Given this list of marker genes PYROXD1, NEFL, GAN, PMP22, STIM1, FLVCR1, DARS2, CHCHD10, DDHD1, COA7, MFN2, KIF1B, POGLUT1, MCM3AP, SPG11, EMD, TMEM240, ALDH18A1, PDK3, SMN1, FZD6, CFL2, FARS2, SPG21, MAG, HEPACAM, LMNA (NCBI Gene Id 7816), TGM6, MECP2, GNB4, NDUFA13, MAP3K20, CWF19L1, KY, SLC5A7 (NCBI Gene Id 60482), CCDC88C, ERLIN2, FZD4, ACTN4, DNA2, GDAP2, SURF1, POMT1, CHKB, ATP1A1, PINK1, PMP2, TOR1AIP1, PRX, DAB1, HNRNPDL, MYOT, TFG, MYH7, IGHMBP2, CPT1C, GRM1, PDE8B, BSCL2, PDYN, AFG3L2, COX6A1, SYT14 (NCBI Gene Id 255928), HSPB3, WARS1, TENM4, GARS1, ALG14, REEP2, FBXO7, RETREG1 (reticulophagy regulator 1), GBE1, TMEM43, MPZ, SIGMAR1, PNPLA2, DPAGT1, SLC25A4, FAT2, ALG2, AIFM1, PEX2, RYR1, EEF2, AR, TIA1, KBTBD13, SETX, DCTN1, TTN, ORAI1, IBA57, ADSS1, KCNC3, MARS1, LRSAM1, MTPAP (mitochondrial poly(A) polymerase), GJB1, TRIM32, CLN8, KCND3, HSPB1, PEX10, DYSF, FN1, COL6A1, GYG1, AP4B1 (adaptor related protein complex 4 subunit beta 1), MTMR14, NLRP3, ACTA1 (NCBI Gene Id 58), ATP6AP2, PRKCG, LRP12, VWA3B, ITPR1, HNRNPA1, FLNC, LAMA2, NOL3, SPTBN2 (spectrin beta, non-erythrocytic 2), C19orf12, HPCA, DNM1L, MCM2, DNM2, FRG1, MYMK, LRRK2, MYPN, ABHD12, DNAJB2, SYNE1, TPP1, RFC1, ELOVL5, RNASET2, MORC2, CLCN5, DZIP1L, CRPPA, DYNC1H1, PLP1, SLC34A2, TEAD1, SCN9A, LRP5, WNK1, FBXO38 (F-box protein 38), MME, PLD3, PARK7, ALS2, DNAJC6, DNAJB6, KIF1A, CRYAB, TBC1D24, CACNA1G, ATP7A, VMA21, here is a description of the gene set: Slowly progressive Applies to a disease manifestation that only slowly increases in scope or severity over the course of time. species: Homo sapiens Human Gene Set: HP_SLOWLY_PROGRESSIVE